Given this list of marker genes DCAF4L1, CNRIP1, IMMT, DENND4B, KHDRBS3, NPTN, SBF2-AS1, NOP56 (NCBI Gene Id 10528), BACH1, ENSG00000275465, TRIM45, ZNF235, DIP2C-AS1, DNPH1, CSNK1A1P1, CLUH, MTMR2, CPSF2, EVA1A, HILPDA, MDFIC, PROM1 (prominin 1), PSMB4, ZNF701 (zinc finger protein 701), PSMD3, RHO, WIZ, ATXN7L3B, IL3RA, UTP18, CASC3, CTSLP8, STAM2, IKBKG, MOSMO, PIK3AP1, IRF6, UGT2B15, ERRFI1, ELP2, CBFB, DTX4, PSMC3, SIGLEC1, CKAP2L, SYT1 (NCBI Gene Id 6857), USP36, NIP7, PFKP, B4GALNT2, CDH9, NXT2, TSG101, KRT14, PLAGL2, GADD45B, ANKRD1, EPB41L5, PSMC4, ZNF227, MRPL46, TMPRSS2, MTHFD2L, DNAAF5, FAM114A2, LSG1, SCN1B, MYOCD, HSPB1, APTX, ZNF672, MRGBP, SEC61A1, FNDC3B, TLR1, SPATA31E1, VPS33A, TMEM69, UGP2, SLC44A4, NIM1K, BCAT1, NUP35, NAA50, IFRD2, ACP5, ZNF234 (NCBI Gene Id 94536), ELP3, TINF2, PPP1R11, SCO1, SNRPG, CLK2, SPATS2L, SMG7, RANBP1, HCN4, YARS2, MARCHF9, TMEM165, DOCK1, SRC (SRC proto-oncogene, non-receptor tyrosine kinase), MRPL3, ZNF302, ZHX2, PDE7A, HSDL1, KRT222, TEDC1, TMUB1, EDEM1, CNOT4, BARX1 (NCBI Gene Id 56033), HNMT, EMD, SEC61G, KHNYN, PHF23, LITATS1, KLHL9, TXNDC9, UBE2DNL, SFT2D2, EGLN2, GAR1, EIF5B, LEO1, ZKSCAN5, ATG101, MUCL1, HIVEP3, RMI1, NIFK, TXNL4B, CHRNA10, SPDL1, LMAN1, SEPHS2, IL6-AS1, KLHL28, RYBP, CLEC3A, PSKH1 (NCBI Gene Id 92137), TNFRSF14, XPO5, SPATA9, CRLF2, RASA3, PACRG-AS3, AGRN, KLHL23 (kelch like family member 23), TMEM41B, GPT2, POLR1C, TOM1, PPP2R1A, RBM28 (NCBI Gene Id 55131), TIFAB, AJUBA, SERINC1, ZNF613, SAMD15, DCLRE1B, ZNF407-AS1, KRTAP3-1, TMEM208, UNC50, SLC30A1, SNRPD3, PSMA1 (proteasome 20S subunit alpha 1), TAF9, MEGF8, MFAP3, CDKN2B-AS1, EML4, DTX2, WFDC1, CDON, WDCP, COL23A1, ZMYND15, PAK1IP1, WDR5B, IBTK, CC2D1B, DDX23, TERB1, MCCC2, ZNF233, RRAGA, ZW10 (zw10 kinetochore protein), ZNF624, GRWD1, IPO9, C1QTNF1, KPNA3 (karyopherin subunit alpha 3), VDAC1, DYNLT3, here is a description of the gene set: studied in species Homo sapiens from publication Hu X, Chung AY, Wu I, Foldi J, Chen J, Ji JD, Tateya T, Kang YJ, Han J, Gessler M, Kageyama R, Ivashkiv LB (PMID 18976936) Human Gene Set: GSE11864_UNTREATED_VS_CSF1_PAM3CYS_IN_MAC_DN Genes down-regulated in comparison of untreated macrophages versus those cultured with M-CSF and Pam3Cys (TLR2 agonist). Gene expression analysis of freshly isolated CD14+ human monocytes and monocytes cultured in the presence or absence of interferon (IFN) -gamma for 24 h and then stimulated with Pam3Cys, a Toll-like receptor (TLR) 2 ligand, for 6 h. Results provide insight into mechanisms by which IFN-gamma reprograms early macrophage differentiation and subsequent response to TLR ligands.